Given this list of marker genes TSC1, SYT1, SPTBN1, AUTS2, FOXP1, MECP2, WDR26, DNAJC19, IFNG, GRN, TSC2, NR2F1, TRANK1, here is a description of the gene set: studied in species Homo sapiens Human Gene Set: HP_REPETITIVE_COMPULSIVE_BEHAVIOR Repetitive compulsive behavior